Given this list of marker genes Grip1, Dbn1, Prkn, Inpp5k, Pip5k1a, Slc30a1 (solute carrier family 30 (zinc transporter), member 1), Ptch1, Clasp2, Fyn, Abhd17a, Reep1, Syngap1, Glrb, Mtmr4, Slitrk3, Stx3, Vti1b, Snap47, Kif2c, Rraga, Vamp8, Fyb1, Kif5b, Rer1, Phaf1, Rilpl1, Pdzk1, Arhgef16, Flot1, Cit, Mff, Bag6, Sec61a1, Stac3, Tmbim1, Frmd8, Tiam1, Cox18, Pls1, Optn, Hectd1, Prnp, Golph3, Chp1, Zdhhc25, Gorasp2, Rtp1, Trem2 (triggering receptor expressed on myeloid cells 2), Cnpy4, Get1, Clip1, Efcab7, Hspa4 (NCBI Gene Id 15525), Syne3, Cacnb1, Itgam, Pex5, Naxe, Pkp2, Epm2a, Vil1, Epha2, Nsf, Emc1, Nptx2, Sptbn4, Llgl2, Dennd1b, Crkl, Vps35l, Itgal, Oxa1l, Sec23a, Cav3, Srp9, Prph2, Wnk3, Adam22, Nsg1, S100a10, Wnk4, Kcnip4, Eps15, Erbb2, Dlg2 (discs large MAGUK scaffold protein 2), Zfand2b, Cacng3, Atp2c2, L1cam, Itgb1, Ins1, Exoc4, Snap23, Nherf1, F11r, Ptn, Arl6ip5, Dennd1a, Emc3, Rab14, Folr1, Neto2, Ccdc93, Rhog, Sec13, Arhgef9, Rab35, Vps26a, Cdh2, Washc1, Akt1, Kif13a, Yjefn3, Golga4, Flna, Hsp90aa1, Ift122, Tomm70a, Hycc2, Shank3, P2ry1, Rtp4, Rapsn, Rab13, Zdhhc3, Commd1, Fis1, Dlg3, Lat, Sh3glb1, Clec2i, Colq, Rab3ip, Sec61g, Apoe, Timm9, Fcgr2b, Lrrc15, Rab6b, Fnta, Itgb2l, Smurf1, Cplx1, Hpca, Lhfpl4, Lypla1, Gga3, Zdhhc5, Tram2, Ager, Tent2, Ncf1, Lztfl1, Rap1a, Cnih2, Mief1, Umod, Ezr, Dchs1 (NCBI Gene Id 73159), Timm10, Grip2, Myadm, Blzf1, Cacna2d2, Sptbn1, Vps26b, Tmem88, Gga1, Ano1 (anoctamin 1, calcium activated chloride channel), Arfgef2, Cacna1a, Zdhhc18, Tmem147, Pex19, Pla2g3, Inpp5f, Ppfia1, Mtch1, Ndufa13, Tspan33, Lamtor1, Tnfaip6, Slc12a5, Pigw, Sec63, Fzd9, Kcne1, Zdhhc19, Lmna, Ankrd50, Dpp6, Ramp3, Sh3pxd2b, Tescl, Dnaja3, Nlgn2, Dnm2, Gpc1 (glypican 1), Gsk3b, Tmem126a, Crk, Mesd, Cmtm6, Ndc1, Grik5, Dusp18, Wdr19, Tomm22, Bsg, Stx6, Slc12a1, Gper1, Rab11fip4, Kcnj11 (potassium inwardly rectifying channel, subfamily J, member 11), Golga7b, Pard3, Zdhhc9, Timm13, Ptprc, Nptx1, Slmap, Rala, Pdcd5-ps, Vps35, Slc51b, Tm9sf4, Snx27, Wdr59, Exoc6b, Gpr179, Def6, Dvl1, Entr1, Shisa6, Atp1b1, Timm22, Tm9sf2, Rab29, Cacng7, Eipr1, Arl5b, Zfyve27, Arl3, Cdh1, Rftn1, Neto1, Tcaf1, Pla2g4e, Sys1, Lrrc4, Folr2, Ccdc47, Epb41l3, Lrrc7, Clstn1, Tm9sf3, Nup54, Cyp46a1, Bid, Bbs1, Nptxr, Vps37d (vacuolar protein sorting 37D), Krt18, Zdhhc14, Nrxn3 (neurexin III), Vps37c, Rab11a, Stx1a, Jsrp1, Actb, Ramp1, Gpc4, Rab34, Pgap2 (post-GPI attachment to proteins 2), Pik3r2, Rab12, Tnf, Dmtn, Itga4, Stx4a, Thy1, Rab5if, Ssh1, Lypd1, Lgals3, Cd24a, Abi3, Fxr1, Atp9a, Myo5b, Dennd1c, Yif1b, Vti1a, Arl5a, Ap3d1, Gpsm2, Jup, Sorbs2, Vps37b, Sec16a, Arpc2, Cacng8, Ogt, Crb3, Nhlrc1, Scn3b, Rab3gap2, Gpc3, Sec62, Map2k1, Bax, Rock2, Tspan5, Rab26, Llgl1, Bag4 (BCL2-associated athanogene 4), Tpbg, Cd81, Arl6ip1, Mal, Pex26, Naca, Cln3, Chm, Rab3gap1, Gga2, Itgb2, Wdr24, Get4, Atad1, Tnfrsf1a, Lgi1, Snx30, Lyplal1, C1ql2, Appl1, Ap3b1, Rab11fip3, Emc9, Vps29, Csnk2a1, Irgm2, Exoc5, Slc4a1, Ccdc88a, Camk2a, Zdhhc21, Rack1, Slc7a11, Rdx, Reep2, Spg11, Ghsr, Exoc6, Mylk, Slc1a1, Srp54c, Nacad, Zdhhc1 (NCBI Gene Id 70796), Pkdcc, Sgta, Sec61b, Dusp21, Rab31, Iqsec2, Tspan9, Arhgap1, Ephb2, Clip3, Mapk10, Lrp4, Itgb3, Lrp5, Git1, Sqstm1, Romo1, Agk, Actn2, Prkci, Grin3b, Olfm2, Gak, Hycc1, Arf6 (NCBI Gene Id 11845), Rtp2, Pdcd5, Ehd2, Grin2c, Tub, Agrn, Errfi1, Fcer1g, Bcl2l1, Tspan15, Hgs, Camk2b, Adcy6, Ift80, Snx31, Snx3, Gabarap, Htr1a, Tm9sf5, Sytl2, Atp1b3, Rab7, Macf1, Steap2, Srprb, Gas6, Amn, Get3, Vps37a, Nme7, C2cd6, Kcnip3, Egfr, Zdhhc12, Ypel4, Caml, Rab11b, Rab8a, Rab11fip2, Bbip1, Musk, Nmt1 (N-myristoyltransferase 1), Mmp14, Slc5a3, Pex3 (peroxisomal biogenesis factor 3), Vps39, Bves, Atp13a1, Adipoq, Pid1, Cdk5, Rtp3, Pacs1, Tmed2, Gpc2, Ikbkb, Cnst, Ramp2, Scrib, Cacng5, Stac, Bbs2, Vps4a, Actr3, Aqp11, Grin2a (glutamate receptor, ionotropic, NMDA2A (epsilon 1)), Mtcl1, Adora1, Numb, Sco1, Dpp10, Rragc, Wdr72, Ppil2, Tmem150a, Emc8, Emp2, Tram1, Arhgap44, C1ql3, Erbb4, Wipf3, Timm29, Maip1, Dab2, Arl4c, Rapgef6 (Rap guanine nucleotide exchange factor (GEF) 6), Arl6, Chmp4b, Dock2, Wnk1, Gripap1, Csk, Tmem108, Dok7, Vps50, Tnik, Cemip, Ar, Lmnb1, Dlg4, Zdhhc22, Vps13b, Arl13a, Ap4m1, Nrxn1, Atp6ap1, Ubl4a, Ehd1, Hspa5, Zdhhc2 (zinc finger, DHHC domain containing 2), Zdhhc20, Myl12a, Ptpn23, Npc1, Srp54a, Vwc2, Pkp1, Tsc2, Stom, Braf, Anxa2, Cacng4, Ppp2r5a, Itgb7, Rapgef2, Ank2, Emc2, Grik2, Rab8b, Camk2d, Gphn, Nrxn2, Rhoq, Emc4, Rock1, Lrrtm4, Necab2, Usp17le, Rab6a, Chrdl1, Nfasc, Ptpn9, Epha3, Dennd4c, Scarb2, Capn3, Tomm40, Frmpd1, Abca12, Ankrd27, Samm50, Srp19, Skap1, Emc10, Stxbp5, Fgf13, Pdpk1, Cltc, Agr2, Hps6, Tmco1, Cacnb3, Stx16, Oga, Tspan14, Large1, Rabep1, Mief2, Fermt2, Nmt2, Ift20, Etv5, Traf6, Prepl, Ehd4, Nomo1, Vps51, Vps53, Grin1, Lama5, Map7, Acsl3, Ndrg4, Gpr158, Micall2, Sacm1l, Camk2g, Stxbp1, Vamp3 (NCBI Gene Id 320838), Mtch2, Cdh13, Gorasp1, Efr3b, Epg5 (NCBI Gene Id 71423), Emc7, Atp2c1, Stxbp5l, Trarg1, Prkcz, Myo5a, Pigr, Zdhhc23, Ins2, Nherf4, Pals1 (NCBI Gene Id 70703), Zdhhc24, Farp1, Stx1b, Rac1, Cdk5r1, Sgtb, Micall1, Arl5c, Moap1, Snf8, Glp1r, Vamp5, Exoc2, Mmgt1, Cacnb2, Dlg1, Sorl1, Lmtk2, Gdi1, Pacs2, Cwh43, Vamp2, Arhgap8, Sesn2, Ccdc22, Rhbdf2, Kalrn, Plekhf1, Vps26c, Cacng2, Reln, Tesc, Stac2, Tmem59, Lmnb2, Prkg2, Vps52, Ttc8, Exoc8, Cript, Tgfb1, Ttc7b, Flot2, Snx4, Ank3, Akap5, Nkd2, Kcnb1, Wnt3a, Pkp3, Golga7, Pak1, Emc6, Zdhhc7, Ttc7, Vamp4, Pacsin1, Srp68, Picalm, Lrp6, Rapgef4 (NCBI Gene Id 71744), Pikfyve, Csrp3, Ppp1r9b, Trmt10b, Ccl2, Ssna1, Akt2, Myo1c, Scp2, Pex16, Wdr83os, Ehd3, Arfrp1, Srpra, Afdn, Magi2, Itgb1bp1, Golph3l, Ank1, Sorbs1, Srp14, Hras, C2cd5, Pik3r1, Bcs1l, Madcam1, Negr1, Srp72, Kcnb2, Acap2, Ap2m1, Fyb2, Snx17, Exoc1, Sec61a2, Tram1l1, Zdhhc15, Snx12, Rabgef1, Rilpl2, Snx7, Ngdn, Palm (paralemmin), Stx12 (syntaxin 12), Zdhhc6, Pgrmc1, Mrap2, Rap2a, Pick1, Efr3a, Rab32, Cnih3, Dag1, Itga3, Nherf2, Ncln, Shisa7, Grin2b, Nlgn1, Bltp1, Lgals9, Fcho2, Gpc6, Gsn, Ldlrap1, Nectin3, Sfn, Rangrf, Rab17, Psap, Cib1, Sirt6, Stx8, Lrp1, Epb41l1, Chic2, Stx7, Adam10, Frrs1l, Cd53, Arl13b, Rab10, Nup155, Tm9sf1 (transmembrane 9 superfamily member 1), Rab38, Zmynd8, Ssr3, Gpc5, Cask, Zdhhc11, Pik3ca, Nbea, Ap2b1, Pram1, Mrap, Atp2b4, Cpe, Zdhhc4, here is a description of the gene set: studied in species Mus musculus Mouse Gene Set: GOBP_LOCALIZATION_WITHIN_MEMBRANE Any process in which a substance or cellular entity, such as a protein complex or organelle, is transported to, and/or maintained in, a specific location within a membrane.